Given this list of marker genes Angptl4, Adam19, Jup, Ctnnb1, here is a description of the gene set: species: Mus musculus Reactome Pathway: Regulation of CDH11 function part of: Regulation of CDH11 Expression and Function This event has been computationally inferred from an event that has been demonstrated in another species.<p>The inference is based on the homology mapping from PANTHER. Briefly, reactions for which all involved PhysicalEntities (in input, output and catalyst) have a mapped orthologue/paralogue (for complexes at least 75% of components must have a mapping) are inferred to the other species. electronically inferred by orthology from the curated human pathway